Given this list of marker genes Rps25, Rps6ka3, Rps23, Rpl32, Rplp0, Rps6kb2, Rpl21, Gm15501, Rpl35, Rpl19, Rpl6, Rps21, Rps20, Rps4x, Rpl8, Rpl41, Rpl36a, Rpl11, Rps3a1, Fau, Rps14, Rpl3, Rpl13 (ribosomal protein L13), Rps5, Rpl27a, Rps26, Rpl31, Rps13, Rpl27, Rps18, Rps27a, Rps6ka1, Rpl35a, Rpl39, Rpl24, Rps6ka2, Rpl12 (NCBI Gene Id 269261), Rps19, Rps24, Rps10, Rpl38, Rps3, Rpl10a, Rpl37, Rps17, Rpl4, Rpl37a, Rplp1, Rps15a, Rps8, Rpl26, Rps12, Rpl13a (NCBI Gene Id 80550), Rps7, Rpl18a, Rpl17, Rpl18, Rps16, Rpl34, Rpl22, Rpl7, Rpl29, Rps28, Rps11, Rpl15, Rpl10, Rpl36, Rpl28, Rps15, Rps2, Rpl30, Rpsa, Rps27, Rpl23a, Rpl37rt, Rpl34-ps1 (NCBI Gene Id 619547), Rpl9, Rps29, Rps6, Rpl7a, here is a description of the gene set: Mouse Gene Set: WP_CYTOPLASMIC_RIBOSOMAL_PROTEINS species: Mus musculus Cytoplasmic ribosomal proteins